Given this list of marker genes CHRNA6, CHRNG, CHRNA2, CHRNA4, CHRNA3, CHRND, CHRNA5, CHRNB3, CHRNB4, CHRNA1 (NCBI Gene Id 1134), CHRNE, CHRNB2, here is a description of the gene set: Human Gene Set: REACTOME_PRESYNAPTIC_NICOTINIC_ACETYLCHOLINE_RECEPTORS Presynaptic nicotinic acetylcholine receptors studied in species Homo sapiens